The following is a description of a gene set: species: Mus musculus An thiol-dependent isopeptidase activity that cleaves SUMO from a target protein to which it is conjugated. Mouse Gene Set: GOMF_DESUMOYLASE_ACTIVITY, and this is the list of marker genes: Uspl1, Senp1, Senp2, Senp3 (NCBI Gene Id 80886), Senp5, Semp2l1, Hint1, Semp2l2a, Desi1, Semp2l2b